The following is a description of a gene set: Human Gene Set: MENON_FETAL_KIDNEY_10_IMMUNE_CELLS species: Homo sapiens from publication Menon R, Otto EA, Kokoruda A, Zhou J, Zhang Z, Yoon E, Chen YC, Troyanskaya O, Spence JR, Kretzler M, Cebrián C (PMID 30166318), and this is the list of marker genes: ACTR2, HLA-DPA1, FTLP3, HLA-A, TMSB10, MAF, CAPZB, EEF1B2P6, VAMP8, S100A6, SH3BGRL3, RPLP1, ARHGDIB (NCBI Gene Id 397), CST3, MYL6, LRRFIP1, KLF6, S100A11, CYBA, SAMHD1, RPL12, IQGAP1, IGSF6, GRB2 (NCBI Gene Id 80715), NEAT1, CNPY3, TUBA1B, TOP1, HLA-DPB1, RBPJ, SAT1, PABPC1, CORO1A, LAPTM5, RPLP2, S100A4, TPT1, TMSB4XP8, TPM3, AIF1, SNHG5, TYROBP, HLA-E, ARPC2, FYB1, ARPC3, PFN1, GPX1, COTL1, TMSB4X, PSAP, UBA52, HLA-C, CCDC88A, CFL1, B2M, FGL2, FOS, RPL27A, RPS15A, RGS10, HLA-DRA, ZFP36L2, MNDA, HLA-DRB1, ARPC1B, CAP1, SRGN, OAZ1, LCP1, RPL27, LST1, ACTB (NCBI Gene Id 60), DAB2, CD74, HLA-B, PTPRC, HLA-DRB6, MEF2C, ATP5F1E, FTL, LGALS1, CYBB